The following is a description of a gene set: The directed movement of zinc(2+) ions from outside of a cell, across the plasma membrane and into the cytosol. studied in species Homo sapiens Human Gene Set: GOBP_ZINC_ION_IMPORT_ACROSS_PLASMA_MEMBRANE, and this is the list of marker genes: SLC39A5, SLC30A5, SLC39A6, SLC39A11, SLC39A12, SLC30A1, SLC39A10, SLC39A8, SLC30A8, SLC39A4, SLC39A14